The following is a description of a gene set: To identify biomarkers that discriminate the aggressive forms of prostate cancer, we performed gene expression profiling of prostate tumors using a genetically engineered mouse model that recapitulates the stages of human prostate cancer, namely Nkx3.1; Pten mutant mice. We observed a significant deregulation of the epidermal growth factor and mitogen-activated protein kinase (MAPK) signaling pathways, as well as their major downstream effectors--the activator protein-1 transcription factors c-Fos and c-Jun. Forced expression of c-Fos and c-Jun in prostate cancer cells promotes tumorigenicity and results in activation of extracellular signal-regulated kinase (Erk) MAPK signaling. In human prostate cancer, up-regulation of c-Fos and c-Jun proteins occurs in advanced disease and is correlated with Erk MAPK pathway activation, whereas high levels of c-Jun expression are associated with disease recurrence. Our analyses reveal a hitherto unappreciated role for AP-1 transcription factors in prostate cancer progression and identify c-Jun as a marker of high-risk prostate cancer. This study provides a striking example of how accurate mouse models can provide insights on molecular processes involved in progression and recurrence of human cancer. Mouse Gene Set: OUYANG_PROSTATE_CANCER_PROGRESSION_DN studied in species Mus musculus Genes down-regulated during prostate cancer progression in mice heterozygotic for both NKX3.1 and PTEN. from publication Ouyang X, Jessen WJ, Al-Ahmadie H, Serio AM, Lin Y, Shih WJ, Reuter VE, Scardino PT, Shen MM, Aronow BJ, Vickers AJ, Gerald WL, Abate-Shen C (PMID 18381418), and this is the list of marker genes: Arfip2, Diras1, Srf, Trib3, Ctnnal1, Baiap2, Arl4a, Mapk8ip3, Gna12, Ighm, Mapk3, Rabl6, Egf, Eral1, Arl3, Ptpn11, Cspg4, Arf4, Spred1, Dab1, Map2k3